The following is a description of a gene set: species: Mus musculus Mouse Gene Set: MARSON_FOXP3_CORE_DIRECT_TARGETS from publication Marson A, Kretschmer K, Frampton GM, Jacobsen ES, Polansky JK, MacIsaac KD, Levine SS, Fraenkel E, von Boehmer H, Young RA (PMID 17237765) Foxp3+CD4+CD25+ regulatory T (T(reg)) cells are essential for the prevention of autoimmunity. T(reg) cells have an attenuated cytokine response to T-cell receptor stimulation, and can suppress the proliferation and effector function of neighbouring T cells. The forkhead transcription factor Foxp3 (forkhead box P3) is selectively expressed in T(reg) cells, is required for T(reg) development and function, and is sufficient to induce a T(reg) phenotype in conventional CD4+CD25- T cells. Mutations in Foxp3 cause severe, multi-organ autoimmunity in both human and mouse. FOXP3 can cooperate in a DNA-binding complex with NFAT (nuclear factor of activated T cells) to regulate the transcription of several known target genes. However, the global set of genes regulated directly by Foxp3 is not known and consequently, how this transcription factor controls the gene expression programme for T(reg) function is not understood. Here we identify Foxp3 target genes and report that many of these are key modulators of T-cell activation and function. Remarkably, the predominant, although not exclusive, effect of Foxp3 occupancy is to suppress the activation of target genes on T-cell stimulation. Foxp3 suppression of its targets appears to be crucial for the normal function of T(reg) cells, because overactive variants of some target genes are known to be associated with autoimmune disease. Direct FOXP3 targets that exhibit consistent transcriptional behavior in hybridoma and in ex vivo T lymphocytes., and this is the list of marker genes: Mapre2, Myc, Slfn2, Zap70, Tgif1, Pou2af1, Gpr171 (G protein-coupled receptor 171), Jak2, Ucp2, Gadd45b, S100a6, Ptpn22, Itk, Irf8, Tnfrsf9, Il2, Ly6a, Nfkbid, Dusp6